Given this list of marker genes MTRFR, MRPL58, GSPT2, MTRF1 (NCBI Gene Id 9617), GSPT1, ETF1, MTRF1L, here is a description of the gene set: Functions in the termination of translation. species: Homo sapiens Human Gene Set: GOMF_TRANSLATION_TERMINATION_FACTOR_ACTIVITY